Given this list of marker genes Ccl21b, Ccl19, Ccl2, Ccl26, Ccl22, Ccl7, Ccl1, Cx3cl1, Ccl4, Ccl11, Ccl24, Ccl21a, Lgals3, Ccl8, Il4, Dapk2, Ccl5, Ccl3, Ccl12, Scg2, Ccr3, Ccl25 (C-C motif chemokine ligand 25), here is a description of the gene set: The movement of an eosinophil in response to an external stimulus. Mouse Gene Set: GOBP_EOSINOPHIL_CHEMOTAXIS species: Mus musculus